The following is a description of a gene set: The process in which a relatively unspecialized cell acquires specialized features of an inner cell mass cell. species: Mus musculus Mouse Gene Set: GOBP_INNER_CELL_MASS_CELL_DIFFERENTIATION, and this is the list of marker genes: Ctr9, Nle1, Nr5a2, Tet1, Lats2, Prdm14, Hnf1b, Lats1, Tfap2c, Sox17